The following is a description of a gene set: species: Mus musculus Mouse Gene Set: GOBP_PODOCYTE_CELL_MIGRATION The orderly movement of a podocyte from one site to another, often during the development of a multicellular organism or multicellular structure. A podocyte is a specialized kidney epithelial cell., and this is the list of marker genes: Kank1, Anln, Actn4, Kank2, Rock1, Daam2, Tesk1, Wdpcp